Given this list of marker genes PPARG, NR1H4, HBA2, ATP8B1, FDXR, CFH (NCBI Gene Id 3076), CYP11B1, CORIN, ABCB4, F5, CD46, STOX1, HELLPAR, LBR, ADGRG6, CYP11B2, EP300, CFI, ABCB11, HBA1, DHPS, SLC25A20, NOS3, here is a description of the gene set: Pregnancy-induced hypertension in association with significant amounts of protein in the urine. Preeclampsia Human Gene Set: HP_PREECLAMPSIA studied in species Homo sapiens